Given this list of marker genes UTP20, RASSF5, ERP29, SLC28A2, PREPL, FAF2, CHI3L1, FAM156A, BCLAF3, EME2, TPH1, ECD, SLC10A3, GLE1, B3GALT2, ITFG2, PRM3, TSR1 (TSR1 ribosome maturation factor), RREB1, TMEM59L, GSTCD, EGR2, LINC00301, LRRCC1, SNAI3-AS1, C1orf141, LIPC, GUF1, ZDHHC6, MTHFD1, MIGA1 (mitoguardin 1), RBP2, WDHD1, YJU2, MCM7, SFXN5, NRG3, CCNE2, PA2G4, RNF183 (ring finger protein 183), LZTFL1, LTA4H, CYLC1, TMEM158, BEX1, VKORC1, CSE1L, HAPLN4, CUL4B, GRN, SLC25A51, CHEK1, ZCCHC18, ZMYM1, FAM3C, ENKUR, CAPN15, TMEM176A, SLC38A1, C15orf62, HGH1, RAB2B, KANSL1L, HMX3, NEFH, IRAK3, TLR9 (NCBI Gene Id 54106), DHRS3, ILF2, ADGRL1, CYP26B1 (cytochrome P450 family 26 subfamily B member 1), INTS6L, EIF4G1, D2HGDH, BLMH, PELP1, XCL1, CCDC70, NUDT12, RAB20, MAGED2, TERF2IP, GGA2, ST8SIA1, SIGLEC7, CDYL2, PTDSS1, NCOA5, DCTD, CMKLR1, COA7, INPP5B, SRP54, HSPH1, IL27RA, SLF2, ALKBH8, CLUAP1, H1-2, TRH, TSPAN32, PTTG1IP, LAMP1, MRC2, EIF2AK4, CCN3, CCDC175, GET4, TNRC6A, HYAL3, RNF217, LPCAT1, LIG1, MGAT4A, C10orf62, KIF13A, ANKRD22, HUWE1 (HECT, UBA and WWE domain containing E3 ubiquitin protein ligase 1), LRIG3, TMEM176B, TTC17, CNOT11, NUDT7, SUOX, MMD, CTTN, HAGH, PLA2G4C, PPM1B, RSU1, LGR4, PEX5, VAT1, TRIM37, COL6A2, PRRC2B, C1QL2, TRIM39, SCAMP1, IRX2, BRAF, PITX2, PAN3, ETF1, MYL10, RSPH6A, PDC, SRSF7, FREY1, ASB2, LARS1, HSD17B11, THAP12, SORCS2, UXS1, URB2, NRGN, TPBG, ENSG00000286190, CA8, GLT8D2, NUDT15, STX2, ARNT, MED22, SRM, REV3L, CKMT1B, DDI2, GSDMA, ASAP1, SAV1, NAT10, ZFP2, COPRS, PXMP2, ZNF536, PRR12, BBS5, RSAD1, CENPP, CHD4, IZUMO1R, BBS2, PDE6C, USP39, DCUN1D2 (NCBI Gene Id 56234), XPOT, TMEM42, CRACDL, LAS1L (NCBI Gene Id 81887), ZBED5, KYAT1, RRP36, PIGH, SLC10A2, SLC38A10, EFR3A, DAGLB, CCR9, here is a description of the gene set: Genes up-regulated in comparison of regulatory T cell (Treg) treated with retinoic acid (tretinoin) versus untreated regulatory T cell (Treg). from publication Hill JA, Hall JA, Sun CM, Cai Q, Ghyselinck N, Chambon P, Belkaid Y, Mathis D, Benoist C (PMID 19006694) Human Gene Set: GSE13306_RA_VS_UNTREATED_TREG_UP CD4(+)Foxp3(+) regulatory T (Treg) cells originate primarily from thymic differentiation, but conversion of mature T lymphocytes to Foxp3 positivity can be elicited by several means, including in vitro activation in the presence of TGF-beta. Retinoic acid (RA) increases TGF-beta-induced expression of Foxp3, through unknown molecular mechanisms. We showed here that, rather than enhancing TGF-beta signaling directly in naive CD4(+) T cells, RA negatively regulated an accompanying population of CD4(+) T cells with a CD44(hi) memory and effector phenotype. These memory cells actively inhibited the TGF-beta-induced conversion of naive CD4(+) T cells through the synthesis of a set of cytokines (IL-4, IL-21, IFN-gamma) whose expression was coordinately curtailed by RA. This indirect effect was evident in vivo and required the expression of the RA receptor alpha. Thus, cytokine-producing CD44(hi) cells actively restrain TGF-beta-mediated Foxp3 expression in naive T cells, and this balance can be shifted or fine-tuned by RA. studied in species Homo sapiens